The following is a description of a gene set: part of: Signal Transduction species: Homo sapiens WNT signaling pathways control a wide range of developmental and adult process in metozoans including cell proliferation, cell fate decisions, cell polarity and stem cell maintenance. The pathway is named for the WNT ligands, a large family of secreted cysteine-rich glycoproteins. At least 19 WNT members have been identified in humans and mice with distinct expression patterns during development. These ligands can activate at least three different downstream signaling cascades depending on which receptors they engage. <br> In the so-called 'canonical' WNT signaling pathway, WNT ligands bind one of the 10 human Frizzled (FZD) receptors in conjunction with the LRP5/6 co-receptors to activate a transcriptional cascade that controls processes such as cell fate, proliferation and self-renenwal of stem cells. Engagement of the FZD-LRP receptor by WNT ligand results in the stabilization and translocation of cytosolic beta-catenin to the nucleus where it is a co-activator for LEF (lymphoid enhancer-binding factor)- and TCF (T cell factor) -dependent transcription. In the absence of WNT ligand, cytosolic beta-catenin is phosphorylated by a degradation complex consisting of glycogen synthase kinase 3 (GSK3), casein kinase 1 (CK1), Axin and Adenomatous polyposis coli (APC), and subsequently ubiquitinated and degraded by the 26S proteasome. <br> In addition to the beta-catenin-dependent transcriptional response, WNT signaling can also activate distinct non-transcriptional pathways that regulate cell migration and polarity. These beta-catenin-independent 'non-canonical' pathways signal through Frizzled receptors independently of LRP5/6, or occur through the tyrosine kinase receptors ROR and RYK. Non-canonical WNT pathways are best studied in Drosophila where the planar cell polarity (PCP) pathway controls the orientation of wing hairs and eye facets, but are also involved in processes such as convergent extension, neural tube closure, inner ear development and hair orientation in vertebrates and mammals. In the PCP pathway, binding of WNT ligand to the FZD receptor leads to activation of small Rho GTPases and JNK, which regulate the cytoskeleton and coordinate cell migration and polarity. In some cases, a FZD-WNT interaction increases intracellular calcium concentration and activates CaMK II and PKC; this WNT calcium pathway promotes cell migration and inhibits the canonical beta-catenin dependent transcriptional pathway. Binding of WNT to ROR or RYK receptors also regulates cell migration, apparently through activation of JNK or SRC kinases, respectively, however the details of these pathways remain to be worked out.<br> Although the WNT signaling pathways were originally viewed as discrete, linear pathways controlled by defined subsets of 'canonical' or 'non-canonical' ligands and receptors, the emerging evidence is challenging this notion. Instead, the specificity and the downstream response appear to depend on the particular cellular context and vary with species, tissue and stage of development. Reactome Pathway: Signaling by WNT, and this is the list of marker genes: RAC3, PDE6A, SOX3, H2BC5, LEF1, H3C15, TCF4, AGO4, TNKS, TLE4, GNG11, ADRM1, PSMD7, PRKCA, RAC2, CCDC88C, PPP2R1B, FZD8, XIAP, FZD7 (NCBI Gene Id 8324), TLE5, PDE6G, PDE6B, CTBP2 (NCBI Gene Id 87435), WNT9B, PRKG1, PORCN, H2AX, CTBP1, WNT16, SOX9, H2AC20, PSMC1, RPS27A, TNRC6C, GNG13, YWHAZ, SMURF1, KLHL12, H2BC26, CXXC4, PPP2CA, PSMD1, PSMB3, KREMEN1, PSMD12, WNT10B, EP300, DAAM1, TCF7, PYGO1, NLK (NCBI Gene Id 51701, nemo like kinase), FZD2, CBY1, UBC, GNB4, WNT8B, PSMD14, PPP2R5D, CLTB, PPP2CB, CREBBP, PSMD6, TNRC6B, USP34, XPO1, TCF7L1, RAC1, PFN1, LGR6, SOX7, GNB2, PPP3CB, TCF7L2, CDC73, GNG5, DVL3, PRICKLE1, AP2S1, LGR5, PSMB2, FZD3, WNT2, PSMD13, CAV1, APC, MYC, PSMA2, WNT1, WNT5A, PPP2R1A, FZD4, GSK3B, SCRIB, SMARCA4, PPP3R1, MIR92b, LRP6, GNAT2, SKP1 (S-phase kinase associated protein 1), GNGT2, GNGT1, PSMA3, RYK, CUL1, H2BC4, BCL9L, PPP2R5C, BCL9, GNAO1, SFRP1, H2BC11 (NCBI Gene Id 8970), SOST, WNT9A, PSMC3, CLTC, BTRC, AGO2, HECW1, DKK4, CUL3, PLCB3, AP2A2, WNT6, KREMEN2, WNT7B, SOX4, AXIN1, SFRP2, CSNK2A2, DVL1, CSNK1A1, PRKCB, RNF146, PSMB4, CSNK2B, AKT2, PSMA6, LRP5, PSMC5, H2BC12, WNT3, PSMB1, H2BC15, H2AC18, SNX3, RUVBL1, TLE3, RSPO2, RNF43, H2BC21, SRY (sex determining region Y), WNT10A, GNB3, FZD6, WDR5, WIF1, VPS26A, AKT1, RUNX3, SEM1, GNG2, CAMK2A, NFATC1, TERT, CSNK1E, MEN1, GNG10, H2AC6, TNRC6A, H2BC14, H3-3A, H2AC7, VPS35, DPY30, H2BC12L, AMER1, CLTA, MOV10, H2BC13, GNG8, RSPO1, RSPO4, H3C1, H2AZ2, WNT2B, PSMC6, PPP2R5A, UBA52, GNG12, PRKG2, H2AC4, TRRAP, PSMD8, GNG7, PSMA4, ITPR3, TNKS2, DACT1, VANGL2, ZRANB1, H2BC1, SMURF2, PSMD2, ARRB2, PPP2R5E, PSMA7, PSMD3, PSMC4, VPS29, PSMB7, TLE2, KRAS, FRAT1, PSMB5, H2AC14, AXIN2, PSMB6, KAT5, PIP5K1B, PSMA5, SOX13, AP2A1, H2BC17, SOX17, WLS, PPP3CA, GNG3, PYGO2, FRAT2, H2AJ, TLE1 (NCBI Gene Id 7088), ASH2L, H4C1, PPP2R5B, PSMC2 (proteasome 26S subunit, ATPase 2), TMED5, PRKCG, WNT11, H2AB1, WNT8A, PLCB1, DVL2, LEO1, WNT4, USP8, PARD6A, CTNNB1, UBB, GNG4, AP2M1, HDAC1, ROR2, H2BC3, RBBP5, CSNK2A1, DKK2, PSMD11, KMT2B, WNT5B, H2BC9, ZNRF3, DKK1, SOX6, ROR1, CSNK1G2, CTNNBIP1, CHD8, PSMA1, H3-4, GNB5, LGR4, AP2B1, AGO1, GNB1, ITPR2, CALM1, RBX1, FZD1, PLCB2, RHOA, RSPO3, SOX2, WNT7A, FZD5, ITPR1, MAP3K7, WNT3A, AGO3